Given this list of marker genes EMX2, SMUG1, RGS7, SF3A3, FRA10AC1, here is a description of the gene set: Genes containing one or more binding sites for (REPIN1) in their promoter regions (TSS -1000,+100 bp) as identified by GTRD version 20.06 ChIP-seq harmonization. Human Gene Set: REPIN1_TARGET_GENES studied in species Homo sapiens from publication Yevshin I, Sharipov R, Kolmykov S, Kondrakhin Y, Kolpakov F (PMID 30445619)